The following is a description of a gene set: species: Mus musculus Mouse genes annotated to increased hepatic hemangioma incidence (MP:0002047) retrieved from the Mouse Genome Informatics database via MouseMine from publication Motenko H, Neuhauser SB, O'Keefe M, Richardson JE (PMID 26092688) Mouse Gene Set: MP_INCREASED_HEPATIC_HEMANGIOMA_INCIDENCE, and this is the list of marker genes: Tsc1, Tsc2, Vhl, Gnmt, Fbxo4